The following is a description of a gene set: Human Gene Set: WP_PEROXIREDOXIN_2_INDUCED_OVARIAN_FAILURE studied in species Homo sapiens Peroxiredoxin 2 induced ovarian failure, and this is the list of marker genes: MAPK10, CYP11A1, PRDX2, PARP2, BAX, HSD3B2, CASP3 (NCBI Gene Id 836), STAR